Given this list of marker genes Sfn, Gadd45a, Pcna, Ccnb1, Bax, Cdk1, here is a description of the gene set: electronically inferred by orthology from the curated human pathway Reactome Pathway: TP53 Regulates Transcription of Genes Involved in G2 Cell Cycle Arrest studied in species Mus musculus This event has been computationally inferred from an event that has been demonstrated in another species.<p>The inference is based on the homology mapping from PANTHER. Briefly, reactions for which all involved PhysicalEntities (in input, output and catalyst) have a mapped orthologue/paralogue (for complexes at least 75% of components must have a mapping) are inferred to the other species. part of: TP53 Regulates Transcription of Cell Cycle Genes